Given this list of marker genes DCTN2, DDR1, CD8A, IL2RB, PPP1CB, IRF1, RCC1, FCGBP, CXCL1, NBL1, ARPC2, SRI, PSMD2, PRKD2, CDH11, IER3, ZNF384, SLA, BLVRA, DAB2, TUBA4A, AP2S1, TSPAN3, HLA-DQA2, HCLS1, AEBP1, GNS, HK1, COL15A1, S100A13, PNP, CBFB, CXCR4, ATP6V1F (ATPase H+ transporting V1 subunit F), LAPTM5, GUCY1A1 (NCBI Gene Id 2982), DDX11, MAP1B (NCBI Gene Id 4131), PTPRC, C3AR1, ARHGDIB, MGP, ARPC1B, HEXA, TMSB4X, PPIC, RALB, CCN1, ID3, CRIP2, CD151, LYN, CDK2AP1, AQP1, CD53, COL4A1, FBRS, HIF1A (hypoxia inducible factor 1 subunit alpha), CAPZA1, LAMB1, SMAD2, ATP6AP1, RALGDS, LTF, CYBA, CTSC, LTBP2, MYCBP2, SLC2A5, RSU1, PCLAF, SMARCD1, ITPR3, GNAI2, TNFRSF1B, CCL5, IL2RG, ANXA5, DUT, PLP2, GPNMB, F13A1, HLA-DQB1, SLC1A5, CDC20, CCL3, LOX, LTBP3, CCND2, ADAM9, POLD3, PPP4C, FGL2, ATP6V0B, CYFIP1, LGALS3BP, HLA-DMA, OAZ1 (ornithine decarboxylase antizyme 1), TRAF5, PLAUR, CCN2, SRGN, FBN1, CSRP3, PYGB, C1QB, ALDOA, COL3A1, COL11A1, PAK1, CHN1 (NCBI Gene Id 27011), GLIPR1, ITGB2, S100A10, ACP5 (NCBI Gene Id 54), LMO4, FLNA, RAB31, STK38 (serine/threonine kinase 38), POSTN, GYPC, ARF5, GEM, BCL2A1, QSOX1, PKN1, LDHB, IQGAP1, TPM2, FCGR2A, CD74, RHOA, FYB1, DNM2, PKMYT1, HLA-DOA, IL15RA, CD47, KLF5, IKBKE, KLC1, SPAG8, TAX1BP3, CDC25B, AIF1, TAGLN, ALOX5AP, ME1, S100A11, DGKA, ATP6V1B2, LHFPL2, M6PR, RNASE6, ANXA4, IFI16, SLC39A6, COL1A2, CD37, ANXA1, ATP1B3, GRN, MSN, CTSS, RPA2, AKT3, LGALS1, PAPSS1, MFAP1, ADAM8, GSTP1, ADAM15 (NCBI Gene Id 8751), DUSP5, CRABP2 (cellular retinoic acid binding protein 2), LGMN, COL6A2, PFN1, IL7R, PPP4R1, CYP1B1, FHL3, TRIP10, SLBP, COL5A2, PROCR, RIN2, TIMP2, IFI30, PGK1, LUM, DDR2, PAM, LGALS9, DGKZ, NSMAF, EFNB1, CORO1A, PKD2, SLC2A1, DPYSL2 (NCBI Gene Id 1808), LCP1, COL4A2, TP53BP1, RNASE1 (ribonuclease A family member 1, pancreatic), TCF4 (NCBI Gene Id 6925), CELF2, IGLL1, PIM2, ACTA2, LITAF, CCR7, EFEMP1, MTHFD2, STX3, PEA15, THY1 (Thy-1 cell surface antigen), CYBB, COL6A1, NPC2, HLA-DPB1, SLC7A5, VCAN, PLD3 (phospholipase D family member 3), ASAH1, CD48, TFF3, IGKC, LSP1, RIT1, IGFBP5, FUT4, CD3D, PRMT5, MPHOSPH6, TRAF3, here is a description of the gene set: Hepatocellular carcinoma (HCC) is a highly heterogeneous disease, and prior attempts to develop genomic-based classification for HCC have yielded highly divergent results, indicating difficulty in identifying unified molecular anatomy. We performed a meta-analysis of gene expression profiles in data sets from eight independent patient cohorts across the world. In addition, aiming to establish the real world applicability of a classification system, we profiled 118 formalin-fixed, paraffin-embedded tissues from an additional patient cohort. A total of 603 patients were analyzed, representing the major etiologies of HCC (hepatitis B and C) collected from Western and Eastern countries. We observed three robust HCC subclasses (termed S1, S2, and S3), each correlated with clinical parameters such as tumor size, extent of cellular differentiation, and serum alpha-fetoprotein levels. An analysis of the components of the signatures indicated that S1 reflected aberrant activation of the WNT signaling pathway, S2 was characterized by proliferation as well as MYC and AKT activation, and S3 was associated with hepatocyte differentiation. Functional studies indicated that the WNT pathway activation signature characteristic of S1 tumors was not simply the result of beta-catenin mutation but rather was the result of transforming growth factor-beta activation, thus representing a new mechanism of WNT pathway activation in HCC. These experiments establish the first consensus classification framework for HCC based on gene expression profiles and highlight the power of integrating multiple data sets to define a robust molecular taxonomy of the disease. species: Homo sapiens Human Gene Set: HOSHIDA_LIVER_CANCER_SUBCLASS_S1 Genes from 'subtype S1' signature of hepatocellular carcinoma (HCC): aberrant activation of the WNT signaling pathway. from publication Hoshida Y, Nijman SM, Kobayashi M, Chan JA, Brunet JP, Chiang DY, Villanueva A, Newell P, Ikeda K, Hashimoto M, Watanabe G, Gabriel S, Friedman SL, Kumada H, Llovet JM, Golub TR (PMID 19723656)